Given this list of marker genes TMEM97, PIGF, IRF4, SNRNP25, COMT (NCBI Gene Id 1312), CSRP2, MKI67, CDC20 (NCBI Gene Id 991), PRKACA, POLR2L, IFI30, CTPS1, CRCP, XPOT, TNFRSF9, KGD4 (NCBI Gene Id 92259), DTD2, MRPS22, FDFT1, TOP2A, GCSH, MOGS, NME4, GZMB, TGDS, NDUFAF4, MZT2B, IFNG (NCBI Gene Id 3458), UCHL1, ELOF1, ARMC1, NUSAP1, MEST, GTF2H4, ARL2, RFC4, TAF11, RSPH3, PRIM2, FDPS, NBN, CCR5, CKAP5, ORC6, PTGR1 (NCBI Gene Id 22949), ENOPH1, CHAF1B, IL2RA, DNMT1, RPN1, TMEM109, MCM5, NDUFS5, PDS5B, CNPY2, IDI1 (isopentenyl-diphosphate delta isomerase 1), NDUFS6, PREP, CDKN2AIPNL, S100A6, PSMD12, MSMO1, CRABP2, NAGLU, CYP51A1, TRAK1, INO80E, MGST3, RNF14, ACAD9, POU2AF1, HASPIN, TPI1, HAUS4, BIRC5, MLLT3, KIF23, UNC119, BUB1, RAD50, TACC3, CRTAP, CKAP2, RRM1, CFAP418, ETFB (NCBI Gene Id 2109), MT2A, TNF, DCK, RCN2, RFC5, OLA1, RAD51AP1, TUBG1, RBPJ, RCC1, EZH2, MNS1, PCLAF, DHCR7, POMP, CHCHD10, FKBP2, PAFAH1B2, MAD2L1, IFT27, CKS1B, RNH1, VCL (NCBI Gene Id 7414), NCBP2, MARCKSL1, PLP2, XPNPEP1, ACOT7, TRIM37, ZDHHC16, GFM1, FKBP11 (FKBP prolyl isomerase 11), IL3RA, DYNLT2, NOCT, XCL1, ZC3HC1, HMBS, CARS1, NFIX, GALK1, MARCKS, MCM2, MRTO4, HAT1, GLRX, DDX1, PMM1, RPA3, LGALS3, MAEA, GMNN, DESI1, ZMIZ2, MRPL17, SYNGR2, PTGER4, LMNB1, CYB5B, LIG1, BCL2A1, BLMH, HK2, CARM1, ENKD1, IRF8, SIVA1, CINP, MT1E, NUP85, POLD2, MAPKAPK2, NCAPH, TAMM41, POLR2F, GADD45G, AIMP2, TSPAN31, CKB, RIOX2, MRPL18, MTX2, SKAP2, SUB1, MRPL2, CHERP, POLR3K, CSNK2A2, MBD4, PGAM1, DCTPP1, NDUFV1, ID1, BRCA1, RNASEH2B, PHTF2, INCENP, IL10RA, CISD1, GIT1, CENPK, MFN1, TIMM9, CDK1, EMC8, TIA1, RFC2, GCAT, WDR43, FAM162A, SFMBT2, CAD, ANXA2, here is a description of the gene set: Human Gene Set: GSE15930_NAIVE_VS_72H_IN_VITRO_STIM_TRICHOSTATINA_CD8_TCELL_DN from publication Agarwal P, Raghavan A, Nandiwada SL, Curtsinger JM, Bohjanen PR, Mueller DL, Mescher MF (PMID 19592655) Differentiation of naive CD8 T cells into cytotoxic effector cells requires three distinct signals- antigen (signal 1), costimulation -B7-1 (signal 2) and cytokine, either interleukin-12 or interferon-a/b (signal 3). Interaction of naive CD8 T cells with antigen and B7-1 programs cell division and proliferation whereas the presence of cytokines- IL-12 or IFNa/b promote survival, differentiation and memory establishment. In the absence of signal 3, the cells interacting with antigen/B7-1 undergo tolerance induction. The objective of this study was to elucidate the mechanisms how the provision of signal 3 promotes differentiation and averts tolerance induction in CD8 T cells. Trichostatin A is a pharmacological agent that inhibits histone deacetylase activity, hence regulating chromatin structure and gene expression and differentiation in many cell types. Gene signature profiles of IL-12, IFNa/b and trichostatin A stimulated cells were compared to elucidate the molecular mechanisms of gene regulation. Oligonucleotide microarray analysis is carried out to determine the extent and molecular nature of the CD8 T cell differentiation program induced by IL-12 or IFNa/b in concert with antigen and B7-1 signal. species: Homo sapiens Genes down-regulated in comparison of CD8 T cells at 0 h versus those at 72 h after treatment with trichostatin A (TSA).